The following is a description of a gene set: studied in species Homo sapiens mouse primary BMDCs were stimulated with tlr ligands and gene expression changes were profiled on Affymetrix arrays from publication Amit I, Garber M, Chevrier N, Leite AP, Donner Y, Eisenhaure T, Guttman M, Grenier JK, Li W, Zuk O, Schubert LA, Birditt B, Shay T, Goren A, Zhang X, Smith Z, Deering R, McDonald RC, Cabili M, Bernstein BE, Rinn JL, Meissner A, Root DE, Hacohen N, Regev A (PMID 19729616) Human Gene Set: GSE17721_0.5H_VS_4H_GARDIQUIMOD_BMDC_UP Genes up-regulated in comparison of dendritic cells (DC) stimulated with Gardiquimod (TLR7 agonist) at 0.5 h versus those stimulated with Gardiquimod (TLR7 agonist) at 4 h., and this is the list of marker genes: ITGA6, SLC50A1, HMG20B, ATP5IF1, UBXN1, GALK2, INTS3, SSBP3, FAM149B1, ACYP1, CLEC4A, DOLPP1, POLD2 (DNA polymerase delta 2, accessory subunit), MRPL15, ADGRE5, HACD4, TMEM129, EEF1AKMT1, PKIG, MRPL44, SEMA6B, VAMP1, ZFP36L2, MFAP1, FIZ1, CYSLTR1, GATD3, TIMP2, PEX3, RIPK3, ATP13A2, GATAD1, ZFP36L1, APOB, MACROH2A1, AKR1A1, ITPKA, DBNDD2, DHX57, MRPS23, PRM3, EHD4, MTX1, GCNT1, PHF5A (NCBI Gene Id 84844), MTX2, BLTP2, NELFE, HACD3, ARSA, VARS1, NDUFS3, ABHD8, SPHK2, KIAA0513, ZMAT3, COQ9, PITPNM1, PLCB2, AP1M1, MTIF2, PER1, GPANK1, SARS1, NKIRAS1, COPS4, NOMO1, TM2D2, MTERF4, IGFBP4, TIMM50, TPK1, TSPAN14, MRPS21, SH2D1B, SF3A1, FANCF, CHCHD7, TFEB, PSMG1, RHOG, B3GNT2, ABHD4, CDK2AP1, HIGD1C (NCBI Gene Id 613227), C14orf119, PTS (NCBI Gene Id 5805), LPCAT1, VPS11, PREPL, UNC119, POLR3GL, EMC6, CCT5, PNKD, METAP2, CPSF3, AMIGO1, AURKAIP1, CSGALNACT2, NUCB2, SLC25A51, DRAP1, C1orf174, SLC7A5, ERLIN1, IARS1, EXOSC8, RGS18, AFG1L, MFSD6, BORCS5, GPR3, NUCKS1, PLEKHO1, PRKCSH, ICOS, BRCA2 (BRCA2 DNA repair associated), FBXL6, LDHA, CLTA, PSPH, GPS1, TAS2R4, POLE3, DUSP19, SURF2, OMA1, MAF1, EGR2, ATRX (NCBI Gene Id 6475), TBL1XR1, GSN, DGKZ, ACOT8, AURKA, ID1, SKIC8, SPG11, SLC38A1, FAM50A, WDR75, HSD11B2, CHMP6, TAF13, FCGR3A, GSTA5, TEX264, SLC35F6, C9orf78, PBDC1, TEDC1 (NCBI Gene Id 283643), SMPD1, DNAJC9, RPL19, EEIG1, ANAPC5, C3orf38, C1QTNF12, UBE2V1, IQGAP2, FES, TBC1D22A, KIF3A, MNT (MAX network transcriptional repressor), ZKSCAN3, ICA1, CAMK2B, COPRS, VPS13C, COMMD9, PRKACA, RNF187, ELAPOR1, TTLL1, UBA2, CISD1, RAP1GAP, UTP20, COQ8A, SIRT7, SLC35A2, MRPL37, NDP, SESN3, POLR2G, RPN1 (ribophorin I), CLNS1A, DPCD, ZSCAN12, DGUOK, SMARCA2, SPTSSA, ASB4, EGR1, GPNMB, PBX1, SNX2, MCUB, PRKAG2